Given this list of marker genes AGAP1, TIMP4, PIM1, CLIP3, SOCS2, FAM86B1, GPRC5A, PCNA, IMPACT, ABHD14A, CCDC102B, GPD1L (glycerol-3-phosphate dehydrogenase 1 like), DSC3, ATP10A, TCF7L2, GNG11, CFH, PAICS, MAP9, NOTCH1, GUCY1B1, CKAP4, PRDX4, PDE3B, AQP9, SAMSN1 (NCBI Gene Id 64092), RRAS2, ABCE1, TLR7, ZC2HC1A, FZD6, NOS1, RBFOX2, ZNF112 (zinc finger protein 112), CREB3L2, PBX1, FAIM, MCTP2, FXYD2, JCHAIN, TNFSF4, LPAR6, XKR8, DUSP22, EXOSC5, TIMP1, CA6, PLA2G4C, ZCCHC14, CD24, ADAMTS1, IL36RN, PDZRN3, NYNRIN, MYEF2 (myelin expression factor 2), SCN9A, UCHL5, TFAM, ERLIN1, IL19, IGLL1 (NCBI Gene Id 8222), KCNK10, UCK2, MFAP4, ULK4, ABCC9, PTGER3, GNL2, WDR41, GPX7, ETF1 (eukaryotic translation termination factor 1), LILRA4 (leukocyte immunoglobulin like receptor A4), CD55, PLPP3, MDFIC, ATIC, MEP1B, STK3, RUBCNL, ZNF460, STOML2, GSTM3, NEK11, RRP1, BAZ2B, EMD, RBM47, DTX4, WDR3, SND1, DHODH, RNF130, PRMT5, TUFT1, METTL8, ZNF550, CD74, WT1-AS, PKD2, MSRB2, BMX, PFKM, EEF1G, GPX1, MICU1, GUCY1A1, VIM, TUBA1A, STOM (stomatin), ZMYND10, FTH1P5, CLCA4, HLA-DMA, IFI44, CYRIA, PRKCA, PON2, S100G, TFRC, ZNF132, GATB, ETFB, LARS2, CTNNA3, XYLT1, BRIP1, RNF144A, ZNF282, IFI44L, CIDEB, LAMC1, ELN, APEX1, GRB14, BMP15, MTCP1, ARMCX1, PLCXD1, TRIM29, TMED3, TBCE, SAMM50, RPS8, DRAM1, SH3BGR (NCBI Gene Id 8211), ADRB3, STN1, SELL (selectin L), SCN3A, ERAL1, LUZP2, IMPDH1, CASP1, TARP, LDB1, PLAC8, CDKAL1, NBN, HACD1, NUBPL, XPOT, IFNA4, OPN3 (opsin 3), MS4A5, PCCB, MEST, GAS6, NHP2, MYOZ2, CDH8 (cadherin 8), ALCAM, POFUT1, TYRP1, HES1, PKIG, POLR3B, RAB40B (RAB40B, member RAS oncogene family), MRE11, GSN-AS1, MRTO4, EIF2B3, MRPL11, RIOX2, CRTAP, SEC31B, INTS7, ELF2, EIF4EBP1, SLC15A3, FAM30A, RUVBL1, RAP1GAP2, MALL, CUL1, ZFP69B, ANXA4, IGF2-AS, PPEF2, here is a description of the gene set: Subpopulations of human fetal thymocyte and circulating naïve T cells were obtained through FACS sorting, including CD3-CD4+CD8- intrathymic T progenitor cells (ITTP), CD3intCD4+CD8+ \double positive\ thymocytes (DP), CD3highCD4+CD8- \single positive\ thymocytes (SP4), CD3+CD4+CD8-CD45RA+CD62L+ naive T cells from cord blood (CB4+), and CD3+CD4+CD8-CD45RA+CD62L+ naive T cells from adult blood (AB4+). Human Gene Set: GSE1460_INTRATHYMIC_T_PROGENITOR_VS_DP_THYMOCYTE_UP species: Homo sapiens Genes up-regulated in comparison of intrathymic T progenitor cells (ITTP) versus CD4 CD8 thymocytes. from publication Lee MS, Hanspers K, Barker CS, Korn AP, McCune JM (PMID 15210650)